Given this list of marker genes BTLA, TNFRSF12A, LY6E, BCAP31, ELP1, IRF2BP1, IRAK1BP1, TIAM2, TNFAIP1, ILF3, here is a description of the gene set: Human Gene Set: WORSCHECH_TUMOR_REJECTION_DN from publication Worschech A, Kmieciak M, Knutson KL, Bear HD, Szalay AA, Wang E, Marincola FM, Manjili MH (PMID 18381452) studied in species Mus musculus We have previously shown T-cell-mediated rejection of the neu-overexpressing mammary carcinoma cells (MMC) in wild-type FVB mice. However, following rejection of primary tumors, a fraction of animals experienced a recurrence of a neu antigen-negative variant (ANV) of MMC (tumor evasion model) after a long latency period. In the present study, we determined that T cells derived from wild-type FVB mice can specifically recognize MMC by secreting IFN-gamma and can induce apoptosis of MMC in vitro. Neu transgenic (FVBN202) mice develop spontaneous tumors and cannot reject it (tumor tolerance model). To dissect the mechanisms associated with rejection or tolerance of MMC tumors, we compared transcriptional patterns within the tumor microenvironment of MMC undergoing rejection with those that resisted it either because of tumor evasion/antigen loss recurrence (ANV tumors) or because of intrinsic tolerance mechanisms displayed by the transgenic mice. Gene profiling confirmed that immune rejection is primarily mediated through activation of IFN-stimulated genes and T-cell effector mechanisms. The tumor evasion model showed combined activation of Th1 and Th2 with a deviation toward Th2 and humoral immune responses that failed to achieve rejection likely because of lack of target antigen. Interestingly, the tumor tolerance model instead displayed immune suppression pathways through activation of regulatory mechanisms that included in particular the overexpression of interleukin-10 (IL-10), IL-10 receptor, and suppressor of cytokine signaling (SOCS)-1 and SOCS-3. These data provide a road map for the identification of novel biomarkers of immune responsiveness in clinical trials. Down-regulated genes defining rejection of mammary carcinoma (MMC) tumors.